Given this list of marker genes SLC25A1, SLC16A10, SLC27A1, SLC1A5, SLCO1A2, SLC22A1, SLC39A4, SLC30A2, SLC9A7, LCN1, SLC26A2, SLC1A1, SLC6A6, SLC11A2, SLC5A12, SLC8B1, SLC28A3, SLC13A5, SLC10A6, SLC35B4 (solute carrier family 35 member B4), SLC2A10, SLC13A3, SLC8A1, RSC1A1, SLC39A6, SLC2A8, SLC4A3, SLC6A9, SLC25A6, SLC25A4, SLC43A2, SLC17A8, SLCO1C1, SLC26A4, SLC9A6, SLC50A1, SLC12A2, SLC5A5, SRI, SLC24A4, SLC5A3, AVP, SLC24A3, SLC67A1, SLC36A2, SLC2A12, SLC5A8, SLC44A2, SLC5A2, LCN9, SLC9A5, SLC29A4, SLCO2B1, SLC9A9, SLC34A3, SLC6A13, SLC7A10, SLC4A9 (NCBI Gene Id 83697), SLC1A7, SLC25A26, SLC22A6, SLC22A16, SLC2A13, SLC17A1, SLC30A8, SLC14A2, SLC1A3, SLC5A6, ARL2BP, SLC4A2, SLC25A29, SLC4A5 (NCBI Gene Id 57835), SLC2A11, SLC15A3, SLC25A22 (NCBI Gene Id 79751), SLCO1B3, SLC22A3, SLC7A1, SLC28A2, SLC6A11, SLC9A3, SLC6A14, SLC2A2, SLC14A1, SLC38A4, SLC41A2, SLC17A5, SLC36A4, SLCO4A1, SLC34A2, SLC24A2, SLC26A6, SLC30A1, SLC2A4, SLCO3A1, SLC41A1, SLC5A4, SLC7A6, SLC2A7, SLC7A5, SLC7A8, SLC6A12, SLC22A12, SLC35D1, SLC8A3, SLC9A2, SLC2A3, SLC12A6, SLC16A7, ARL2 (NCBI Gene Id 402), SLC24A5, SLC38A5, SLC5A7 (NCBI Gene Id 60482), SLC15A4, SLC8A2, SLC6A7, SLC40A1, SLC30A10, SLC34A1, SLC25A18, SLC44A1, SLC28A1, SLC39A2, SLC7A7, SLC6A19, SLC25A5, SLC4A1, SLC1A6, SLC12A7, CTNS, SLC29A1, SLC35D2, SLC29A3, SLC39A10, SLC25A10, SLC39A3, SLC26A7, SLCO4C1, SLCO2A1, SLC29A2, SLC3A1, SLC13A2, SLC22A15, AHCYL2, SLC35A3, SLC2A9 (solute carrier family 2 member 9), SLC45A3, SLCO1B1, SLC16A8, SLC39A5, SLC6A15, SLC4A10 (solute carrier family 4 member 10), SLC12A4, SLC16A2, CP, SLC22A7, SLC27A6, SLC22A8, SLC39A8, SLC26A1, SLC6A4, SLC22A4, SLC5A11, SLC38A2, SLC30A5, MIR32, SLC26A9, SLC2A1, SLC9A1, SLC44A5, SLC7A11, SLC26A11, SLC38A1, SLC13A1, SLC47A2, SLC12A5, SLC26A3 (solute carrier family 26 member 3), SLC7A2 (NCBI Gene Id 6542), SLC4A7, SLC43A1, SLC44A4, SLC31A1, SLC7A9, LCN12, SLC16A3, SLC5A10, SLC2A6, SLC5A1, PDZD11, SLC9A4, BSG, SLC27A4, SLC25A11 (solute carrier family 25 member 11), SLC13A4, SLC17A7, SLC36A1, SLC35A1, SLC4A8, SLC24A1, SLC6A2, SLC3A2, SLC1A4 (NCBI Gene Id 6509), SLC44A3, SLC6A5, SLC1A2, LCN15, SLC35A2, FGF21, SLC2A14, SLC6A1, SLC12A1, SLC6A3, SLC33A1, SLC38A3, SLC32A1, SLC20A1, SLC11A1, SLC20A2, SLC5A9, SLC6A20, SLC35B2, SLC17A6, EMB, SLC39A1, SLC30A3, HEPH, SLC35C1, SLC12A3, SLC22A11, CALM1, SLC7A3, SLC39A14, SLC16A1, SLC35B3, RUNX1, SLC60A2, SLC39A7, APOD, SLC4A4, SLC47A1, SLC15A1, SLC9A8, SLC22A5, SLC22A2, here is a description of the gene set: part of: Transport of small molecules species: Homo sapiens Reactome Pathway: SLC-mediated transmembrane transport Proteins with transporting functions can be roughly classified into 3 categories: ATP-powered pumps, ion channels, and transporters. Pumps utilize the energy released by ATP hydrolysis to power the movement of the substrates across the membrane, against their electrochemical gradient. Channels at the open state can transfer the substrates (ions or water) down their electrochemical gradient, at an extremely high efficiency (up to 108 s-1). Transporters facilitate the movement of a specific substrate either against or following their concentration gradient, at a lower speed (about 102 -104 s-1); as generally believed, conformational change of the transporter protein is involved in the transfer process.<br><br>According to the Human Genome Organization (HUGO) Gene Nomenclature Committee, all human transporters can be grouped into the solute-carrier (SLC) superfamily (http://www.genenames.org/genefamilies/SLC). Currently, there are 55 SLC families in the superfamily, with a total of at least 362 putatively functional protein-coding genes. At least 20-25% amino-acid sequence identity is shared by members belonging to the same SLC family. No homology is shared between different SLC families. While the HUGO nomenclature system by definition only includes human genes, the nomenclature system has been informally extended to include rodent species through the use of lower cases letters (e.g., Slc1a1 denotes the rodent ortholog of the human SLC1A1 gene). And it's worthwhile to mention that pumps, channels and aquaporins are not included in SLC superfamily.<br><br>To date, nine SLC gene families (SLC4, SLC5, SLC8, SLC9, SLC12, SLC20, SLC24, SLC26 and SLC34) comprise the group that exclusively transports inorganic cations and anions across membranes. A further eight SLC gene families (SLC1, SLC6, SLC7, SLC16, SLC25, SLC36, SLC38 and SLC43) are involved in the transport of amino acids and oligopeptides. Two gene families are responsible for glucose transport in humans. SLC2 (encoding GLUTs) and SLC5 (encoding SGLTs) families mediate glucose absorption in the small intestine, glucose reabsorption in the kidney, glucose uptake by the brain across the blood-brain barrier and glucose release by all cells in the body (Wood & Trayhurn 2003).<br><br>SLC transporters are able to transport bile salts, organic acids, metal ions and amine compounds. Myo-Inositol is a precursor to phosphatidylinositols (PtdIns) and to the inositol phosphates (IP), which serve as second messengers and also act as key regulators of many cell functions. Mono-, di- and tri-carboxylate transporters mediate the transport of these acids across cellular membranes. Essential metals are transported by metal-transporting proteins, which also control their efflux to avoid toxic build-up. The SLC6 gene family encodes proteins that mediate neurotransmitter uptake in the central nervous system (CSN) and peripheral nervous system (PNS), thus terminating a synaptic signal. Urea transport is particularly important in the process of urinary concentration and for rapid urea equilibrium in non-renal tissues. Choline uptake is the rate-limiting step in the synthesis of the neurotransmitter acetylcholine. SLC genes SLC5A7 and the SLC44 family encode choline transporters. The SLC22 gene family of solute carriers function as organic cation transporters (OCTs), cation/zwitterion transporters (OCTNs) and organic anion transporters (OATs). They play important roles in drug absorption and excretion. Substrates include xenobiotics, drugs, and endogenous amine compounds (Koepsell & Endou 2004).<br><br>The human SLC5A6 encodes the Na+-dependent multivitamin transporter SMVT. SMVT co-transports biotin (vitamin B7), D-Pantothoate (vitamin B5) and lipoic acid into cells with Na+ ions electrogenically. Four SLC gene families encode transporters that play key roles in nucleoside and nucleobase uptake for salvage pathways of nucleotide synthesis, and in the cellular uptake of nucleoside analogues used in the treatment of cancers and viral diseases. The human gene SLC33A1 encodes acetyl-CoA transporter AT1. Acetyl-CoA is transported to the lumen of the Golgi apparatus, where it serves as the substrate of acetyltransferases that O-acetylates sialyl residues of gangliosides and glycoproteins. Nucleotide sugars are used as sugar donors by glycosyltransferases to create the sugar chains for glycoconjugates such as glycoproteins, polysaccharides and glycolipids. The human solute carrier family SLC35 encode nucleotide sugar transporters (NSTs), localised on Golgi and ER membranes, which can mediate the antiport of nucleotide sugars in exchange for the corresponding nucleoside monophosphates (eg. UMP for UDP-sugars). Long chain fatty acids (LCFAs) can be used for energy sources and steroid hormone synthesis and regulate many cellular processes such as inflammation, blood pressure, the clotting process, blood lipid levels and the immune response. The SLC27A family encode fatty acid transporter proteins (FATPs) (Anderson & Stahl 2013). The SLC gene family members SLCO1 SLCO2 and SLCO3 encode organic anion transporting polypeptides (OATPs). OATPs are membrane transport proteins that mediate the sodium-independent transport of a wide range of amphipathic organic compounds including bile salts, steroid conjugates, thyroid hormones, anionic oligopeptides and numerous drugs (Hagenbuch & Meier 2004).